The following is a description of a gene set: Human Gene Set: PID_TGFBR_PATHWAY species: Homo sapiens from publication Schaefer CF, Anthony K, Krupa S, Buchoff J, Day M, Hannay T, Buetow KH (PMID 18832364) TGF-beta receptor signaling, and this is the list of marker genes: TAB2, CTNNB1, SPTBN1, SMAD4, DAB2, RNF111, DYNLRB1 (NCBI Gene Id 83658), TGFB1 (transforming growth factor beta 1), TGFB2, EIF2A, NEDD4L, ARRB2, RPS6KB1, RHOA, TGFB3, SMAD7, OCLN, PPP1CA, YWHAE, DACT2, SMAD3, SHC1, PPP1R15A, PDPK1, ZFYVE9, AXIN1, TGFBR3, SMURF1, TGFBR2, WWP1, ZFYVE16 (NCBI Gene Id 9765), SMAD2, MAP3K7, SOS1, CCN2, CAMK2A, PML, PPP2CB, PARD6A, SKIL, PPP2CA, TGFBR1, FKBP1A, CAV1, ITCH, BAMBI, YAP1, TAB1, GRB2, PPP2R2A, DAXX, SMURF2, XIAP, STRAP